Given this list of marker genes COMMD7, FAM3D, SOWAHA, DNTTIP1, BOLA1, BOLA3, TMA7, C12orf60, CYBC1, CXXC1P1, EEF1D, CAPZA3, LINC02880, MFSD12, DCP2, ALDH6A1, ASMTL-AS1, FAM47A, NDNF, CD40LG, DACT1, ERLEC1, AP3M1, TRAPPC11, ARHGEF19, CHD9, CCL4, AGPS, CAMK1D, CARD19, DCHS2, FUNDC1, EIF2AK3, CASP3 (NCBI Gene Id 836), FAM21EP, CCDC110, CALCA, EIF3J, DDAH2, LINC01588, CREB3L4, ADAMTSL3, C4orf36, DYNC1I1, ADCY9, ALX4, CYLD, INTS6L, CYTIP, COL10A1, DAAM2, BHLHE22, ADCY7, CENPF, ANKRD52, CLCN3, DPYS, CHRNA1, TLCD3B, ALKBH7, CTTNBP2, C2orf15, CETN2, CMTM5, CFAP298, ERP29 (NCBI Gene Id 10961), CDK5RAP2, KIF9-AS1, CENPE, CNNM4, FAM9A, ECM2, DMTN (NCBI Gene Id 2039, dematin actin binding protein), COL5A1, CDK1, CASP12, EFCAB10, DNAJC28, ZGRF1, EFR3A, CRYBG1, CYMP, FAM118B, DHX58, EIF2AK2, CDC26, ARHGAP21, TBC1D32, ANKRD34A, LAMP5 (lysosomal associated membrane protein family member 5), DUS1L, CXCL14 (NCBI Gene Id 9547), AFAP1, CRBN, CYBA, BBOX1, AKR1A1, EEF1E1, LINC02210 (long intergenic non-protein coding RNA 2210), AKAP9, TMEM242, FAM47C, CCDC152, DMBX1, CNPY1 (canopy FGF signaling regulator 1), ATOH7, BLCAP, CC2D1B, DNAH12, DNAJB14, BID (NCBI Gene Id 637), DOC2A, TRMT13, DDX18, ALK, CHAF1A, C19orf48P, BMS1P1, CABLES1, CAMSAP2, ATP6AP1, DCAKD, CTSC, CACNG7, CGNL1, FDCSP, EVL, CSPG5, CCDC15, ANO8, AP1M1, ZBTB7C-AS2, PRDM16-DT, SUCO, BTAF1 (B-TFIID TATA-box binding protein associated factor 1), CCDC115, BCL11A, ASB3, EXOSC1, BCS1L, ARIH1, SAXO4, AMPD2, DUSP14, ATP13A5, ACVR2A, DAD1, ARPIN, BBS1, CPNE9, FAM111B, ASB15 (ankyrin repeat and SOCS box containing 15), DDX24, FITM1, FCSK, ASAP2, CCDC28B, CA8, FOXRED2, ACAT1, DLD, CTAG2, ALDH16A1, ANAPC7, COTL1, EP400P1, EYA3, DDT, CD248, CHCHD1 (NCBI Gene Id 118487), C17orf75, EIF3K, CSNK2B, EXOC7, FAM50A, DOCK2, ATF7, ARHGAP35, MCUB, C2CD2, ETV6, FAM181B, FBXL14 (F-box and leucine rich repeat protein 14), XKR8, C9orf85, ETS1, ECM1, ETNK2, TMEM263, AGTPBP1, BCL3, BCOR, ENPP7, LINC03040, here is a description of the gene set: Gene expression profiles of subsets of CD4+ T cells according to their expression of FoxP3 and CD45RA were compared. FoxP3 is a key transcription factor for the development and function of natural CD4+ regulatory T cells (Tregs). Here we show that human FoxP3+CD4+ T cells are composed of three phenotypically and functionally distinct subpopulations: CD45RA+FoxP3low resting Tregs (rTregs) and CD45RA-FoxP3high activated Tregs (aTregs), both of which are suppressive in vitro, and cytokine-secreting CD45RA-FoxP3low non-suppressive T cells. The proportion of the three subpopulations characteristically altered in cord blood, aged individuals, and patients with immunological diseases. Terminally differentiated aTregs rapidly die while rTregs proliferate and convert into aTregs in vitro and in vivo as shown by the transfer of rTregs into NOD-scid-common gamma-chain-knockout mice and by TCR sequence-based T cell clonotype tracing in peripheral blood of normal individuals. Taken together, the dissection of FoxP3+ cells into subsets enables one to analyze Treg differentiation dynamics and interactions in normal and disease states, and to control immune responses through manipulating particular FoxP3+ subpopulations. Human Gene Set: GSE15659_NAIVE_CD4_TCELL_VS_RESTING_TREG_UP species: Homo sapiens from publication Miyara M, Yoshioka Y, Kitoh A, Shima T, Wing K, Niwa A, Parizot C, Taflin C, Heike T, Valeyre D, Mathian A, Nakahata T, Yamaguchi T, Nomura T, Ono M, Amoura Z, Gorochov G, Sakaguchi S (PMID 19464196) Genes up-regulated in comparison of naive CD4 T cells versus resting regulatory T cell (Treg).